Given this list of marker genes ZBED4, HASPIN, SKA2, H2BC18, USPL1, DBNL, CIR1, ATP13A1, CENPT, BEX3, PRELID2, RAD51, CACTIN, ABHD12, RAD54L, PLK1, ECT2, FIGNL1, GK5, NTN4, MAGI3, ALDH7A1, GALNT2, MELK, CAP2, P2RX4, AAGAB, IQGAP1 (NCBI Gene Id 8826), ARID2, ATAD5, CCDC34, MASTL, CD27, RAB3D, MS4A2, STX3, ZFAND4, ZBTB18, RB1, PTGFRN, ITFG2, ASF1B, RRM1, EXPH5, PRICKLE1, CEPT1, TWNK, CNIH4, KIF2C, WTAP, VCL, CENPP, MFSD8, ARHGEF10, PLSCR3, TRIM37, CDK6, SOX4 (SRY-box transcription factor 4), CHDH, MIS18BP1, CBX1, UBE2E3, WDR83OS, SAFB, SLC16A10, SUOX, EZH2, EPM2AIP1, RRAS2, SRP68, EIF2B4, FUT8, FABP5, SASS6, NUSAP1, RAB4A, FRAT2, VCAN, KLF10, PPM1L, PARPBP, TUBE1, DMTF1, SKP2, SCPEP1, ENO2, ITM2A, E2F8, CDC6, ANKRD23, ESPL1, C4orf46, ADGRL1, PRR11, SUPT16H, IFT140, SSTR2, NIBAN3, EEIG2, ZNF157, DDIAS, PBK, C19orf53 (NCBI Gene Id 28974), NDRG1, TIMELESS, MCM10, WDSUB1, SLC15A1, NEDD4, ALOX5AP, ARMCX1, PRKRA, ITPR2 (NCBI Gene Id 3709), CBX2, IRGQ, RAD51AP1, IGF2BP3 (insulin like growth factor 2 mRNA binding protein 3), NNT, DEPDC7, CCNF, SLC35D1, UHRF1, PSD3, CEP290, CDK1, SIPA1, PRKAR1A, BLM, CENPE, SNRNP27, ERMARD, IFT81, LZTFL1, ZNF600, CXXC5, FRMD6, AP3S1, RNASE6, PTPRF, CDK2, ALYREF, SMC5, PDE5A, CTSC, TTK, DEPDC1, RAP1GAP2, PRC1, ANKRD37, RAB3GAP1 (RAB3 GTPase activating protein catalytic subunit 1), SFI1, ZNF22, HEMGN, CENPA, RPL7L1, C1orf21, GOLM2, LIG4, RNF14, CHST15, TOP2A (DNA topoisomerase II alpha), TXN, CAP1, E2F2, ALDH5A1, TNKS, PRKAR2B, MCM7, TTC5, DSCC1, CKS1B, CCNB1IP1, UBE2C, PCNA, ABHD17C, MED1, ZFYVE28, DDX39B, C2orf76, PRIM1, CDC20, TBC1D19, BTBD9, HAL, HACD1 (NCBI Gene Id 9200), NCAPH (NCBI Gene Id 679), NCAPG2, ZNF212, RALGPS1, SGO2, STRIP2, MARCKS, PFKP, CDCA5, EIF4E3, GZMA, IL17RB (NCBI Gene Id 55540), ZDHHC21, CCND3, STON1, here is a description of the gene set: Comparisons of global gene-expression profiles revealed a greater distinction between CD4+ Treg cells and CD4+ conventional (Tconv) T cells residing in abdominal (epidydimal) fat versus in more standard locations such as the spleen, thymus and LN. from publication Feuerer M, Herrero L, Cipolletta D, Naaz A, Wong J, Nayer A, Lee J, Goldfine AB, Benoist C, Shoelson S, Mathis D (PMID 19633656) Human Gene Set: GSE7852_LN_VS_THYMUS_TCONV_DN Genes down-regulated in comparison of lymph node conventional T cells versus thymus conventional T cells. studied in species Homo sapiens